Given this list of marker genes GHSR, ARRDC3, GRIA1, DRD2, VPS35, GNB3, here is a description of the gene set: Any process that modulates the frequency, rate, or extent of the self-propelled movement of a cell or organism from one location to another in a behavioral context; the aspect of locomotory behavior having to do with movement. Human Gene Set: GOBP_REGULATION_OF_LOCOMOTION_INVOLVED_IN_LOCOMOTORY_BEHAVIOR species: Homo sapiens